The following is a description of a gene set: Human Gene Set: HOFFMANN_IMMATURE_TO_MATURE_B_LYMPHOCYTE_UP Gene expression profiles of five consecutive stages of mouse B cell development were generated with high-density oligonucleotide arrays from as few as 2 x 10(4) ex vivo isolated and flow-cytometrically purified cells. Between 2.8% and 6.8% of all genes change on differentiation from one cellular stage to the next by at least twofold. The entire pathway involves differential expression of 10.7% of all genes. Previously known expression patterns of genes (like surrogate light chain, RAG-1/2, MHC class II, mel-14 antigen) are confirmed. The gene expression patterns of the proliferating pre-BI and large pre-BII cells on the one hand, and the resting immature and mature B cells on the other hand, are most similar to each other. Small pre-BII cells display a pattern that is transitional between these two groups. Most of the genes expressed in early precursors are involved in general processes, like protein folding or cell cycle regulation, whereas more mature precursors express genes involved in more specific molecular programs (cell surface receptors, secreted factors, and adhesion molecules, among others). Between 19 and genes share a given expression pattern. Combining knowledge about gene function and expression pattern allows identification of novel candidate genes potentially involved in self-maintenance of pre-BI cells, allelic exclusion and pre-B cell receptor signaling in large pre BII cells, cell-cycle arrest of small pre-BII cells, propensity toward apoptosis or anergization in immature B cells, propensity toward cell division and activation in mature B cells, and stage-specific interactions with stromal cells in the bone marrow. Genes up-regulated during differentiation of immature to mature B lymphocyte. species: Mus musculus from publication Hoffmann R, Seidl T, Neeb M, Rolink A, Melchers F (PMID 11779835), and this is the list of marker genes: TUBA3D, RABAC1, CDK5R1, LRFN4, POU5F1, FGF19, RAB6B, ARL2, PCK2, HLA-DQA2, STAT4, GIMAP4, GAD1, CMAHP, OXA1L, CSF1, FCGRT, RFLNB, EEIG1, MS4A6A, ENTPD6 (ectonucleoside triphosphate diphosphohydrolase 6), JAK2, ARRB1, ZFPM2, RPA1, SELL, SIAE, FXYD5, PBX3, RHOH, PACS1, NGEF, NEU1, CIITA, CENPA, BGLAP, BCL2, CUX2, CR2, APOE